The following is a description of a gene set: Neighborhood of JAG1 species: Homo sapiens Neighborhood of JAG1 jagged 1 (Alagille syndrome) in the MORF expression compendium Human Gene Set: MORF_JAG1, and this is the list of marker genes: JRK, ECE1, FOSL1, TMEM94, MC5R, CHST7, PAX9, SULT2B1, RAP1A, RPS6KB2, LTBP4, HOXD4 (homeobox D4), GJB5, GPATCH8 (NCBI Gene Id 23131), CPZ, COX6A2, CYP2A6, AMFR (autocrine motility factor receptor), ZKSCAN3, ATP6V1B1, CD6, MFN1, KRT33A, MC2R, SLC22A24, NCKIPSD, MYO9B, SLC30A3, ENTREP1, SLC24A1, DNAJC16, CALCOCO1, PRELID3A, GRIK5, MT4 (NCBI Gene Id 84560), MSX1, ZNF133, HTR4, FUT6, DPT, PIK3CB, ATP6V0A2, JAG1, BAHD1, DAPK2, SLC16A5, ITIH4, KLHL18, ZNF500, ABO, AQP5 (aquaporin 5), TNFRSF25, HTR7, KRT86, PIGR, WDR62, PCGF1, PRKACA, ECE2, FDXR, GLE1, IL13, PAX8, AQP7, BTD, TBC1D22A, FNTB, IKBKE, SLC2A1, STK17A, SEZ6L, COL18A1, SDC3, GRIP2, PAXIP1, SLC22A6, PIGB, ZNF592, MPP2, TBX5, F7, ARC, TMPRSS6, SH2B1, SLC4A3, SPEF1, BCL2, TMEM11, CYP11A1, CLOCK, EXTL3, BPHL, PLEKHB1, TMCC1, TUBGCP4